The following is a description of a gene set: Human Gene Set: BYSTROEM_CORRELATED_WITH_IL5_DN from publication Byström J, Wynn TA, Domachowske JB, Rosenberg HF (PMID 14525773) Interleukin-5 (IL-5) is a hematopoietic differentiation factor that promotes the development of mature eosinophils from progenitors in bone marrow. We present a multifactorial microarray study documenting the transcriptional events in bone marrow of wild-type and IL-5-deficient mice at baseline and in response to infection with Schistosoma mansoni. The microarray data were analyzed by a 4-way subtractive algorithm that eliminated confounding non-IL-5-related sequelae of schistosome infection as well as alterations in gene expression among uninfected mice. Among the most prominent findings, we observed 7- to 40-fold increased expression of transcripts encoding the classic eosinophil granule proteins (eosinophil peroxidase, major basic protein, the ribonucleases) together with arachidonate-15-lipoxygenase and protease inhibitor plasminogen activator inhibitor 2 (PAI-2), in the IL-5-producing, infected wild-type mice only. This was accompanied by increased transcription of genes involved in secretory protein biosynthesis and granule-vesicle formation. Interestingly, we did not detect increased expression of genes encoding eosinophil-related chemokine receptors (CCR1, CCR3) or members of the GATA or CCAAT/enhancer binding protein (C/EBP) transcription factor families. These data suggest that the IL-5-responsive progenitors in the mouse bone marrow are already significantly committed to the eosinophil lineage and that IL-5 promotes differentiation of these committed progenitors into cells with recognizable and characteristic cytoplasmic granules and granule proteins. Genes whose expression in bone marrow samples correlated inversely with increased levels of serum IL5. species: Mus musculus, and this is the list of marker genes: ADAM10, CEACAM1, LYST, PTPRJ, NR3C1, EIF4G1, HIVEP2, RAB10, INCENP, ERCC2, PAPOLA, SF3B1, MXD1, DDB1, ZFY, IL6ST, TRAM1, CLK4, MAPK9, WRN, IKZF1, HIPK1, ADAR, ITGAL, SORL1, ARNT, CD180, AP1G1 (adaptor related protein complex 1 subunit gamma 1), RNF13, CD44, PIM1, MAPKAPK2, SRSF1, BAZ1B, PITPNB, PLD1, STAT5B, TMPO, CYBB, MTMR1, SNX2, SSR3, FOXM1, SLFN12, NCF1, KLRK1, PIK3R1, HCFC1, CAND1, RNF2, NVL, PIK3CD, PKNOX1, MATR3 (matrin 3), SYK, SLA, KPNA3, TFDP1, PSTPIP2, ZNF22